Given this list of marker genes Mocs2 (molybdenum cofactor synthesis 2), Sult6b1, Sult2a5, Hs6st1, Sugct (succinyl-CoA glutarate-CoA transferase), Ndst2, Sult2a4, Sult1b1, Lias, Chst12, Gal3st2c, Oxct1, Acaa1b (NCBI Gene Id 235674), Sult2a7, Oxct2a, Oxct2b, Sult6b2, Ndst4, Sult4a1, Chst3, Gal3st3, Hs6st2, Hs3st2, Tpst2, Hs3st1, Hs2st1, Sult5a1, Sult1c1, Gal3st2 (galactose-3-O-sulfotransferase 2), Sult1d1, Hs6st3, Sult2a8, Sult2b1, Chst11, Wscd1, Hs3st3a1, Ndst3, Cdkal1, Ndst1, Mocs3, Sult2a3, Chst1, Dsel, Chst14, Chst9, Hs3st6, Tstd3, Tpst1, Mocos, Sult2a6, Hs3st5, Sult3a1, Mpst, Sult2a2, Gal3st4, Cdk5rap1, Hs3st3b1, Chst8, Acsm3, Nfs1, Sult1e1, Acaa1a, Tst, Sult2a1, Gal3st1, Chst15 (NCBI Gene Id 77590), Ust, Sult1c2, Chst10, Sult3a2, Chst2, Chst13, Sult1a1, Chst4, Ctu2, Hs3st4, Gal3st2b, Chst7, Wscd2 (WSC domain containing 2), Chst5, Trmu, here is a description of the gene set: Mouse Gene Set: GOMF_TRANSFERASE_ACTIVITY_TRANSFERRING_SULPHUR_CONTAINING_GROUPS Catalysis of the transfer of a sulfur-containing group from one compound (donor) to another (acceptor). species: Mus musculus